The following is a description of a gene set: Mouse Gene Set: REACTOME_VLDL_CLEARANCE VLDL clearance studied in species Mus musculus, and this is the list of marker genes: Apobr, Apob, Vldlr, Apoc4, Apoc1